The following is a description of a gene set: Human Gene Set: GOMF_PHOSPHORYLASE_KINASE_ACTIVITY species: Homo sapiens Catalysis of the reaction: 4 ATP + 2 phosphorylase b = 4 ADP + phosphorylase a., and this is the list of marker genes: PHKG2, ELP3, PHKA1, ELP4, PHKA2, PRKAG2, PHKG1